Given this list of marker genes UFD1, HYDIN, KMT2D, CEP41, TCF19, CSNK1G3, LIN7C, KIAA1217, KPNA6, EIF3J, GRM7, NEGR1, CACNA2D1, SUSD6, TRIM4, PRKAG2, KHNYN, SEZ6L, CDH2, CLU (clusterin), FBXO11, KANSL1L, HLA-G, GATAD2A, SEL1L, KCNQ3, PPIP5K2, TEX35, ZNF124, ANK2, LIMD2, ANKRD13A, MAPK10, ELAVL4, OPHN1, MVB12B, PYURF, PSMC6, NGEF (NCBI Gene Id 25791), LRRC73, MAGI3, HOOK3 (hook microtubule tethering protein 3), ENKD1, GBP4, KLRD1, POLR2J2, KIF5B, HPSE, PARP15, OSBPL6, VDAC1, RAB11FIP4, RIMS2, BTRC, SMG5, EPPIN, ELP1 (elongator acetyltransferase complex subunit 1), KLF17, CENPS, NXPH1, ZNF131, ABCF2, GLIPR1L2, NOTCH2, SPC25, IDH3A (NCBI Gene Id 3419), PIP5K1C, XKR9, RNF38, FNDC5, CD3E, UBE2G1, CPEB3, CSMD3 (NCBI Gene Id 317683), TRIM71, PAIP1 (poly(A) binding protein interacting protein 1), HOXD13, CCDC140, HIF1AN, SAMD9 (NCBI Gene Id 54809), SLAIN2, MAP4K4, TNFRSF21, USP38, CD276, FGF5, HLA-DPB1, TCAF2, ZFPM2, RGS4, SLC9A4, ZFAND5 (zinc finger AN1-type containing 5), MBNL1, POLR2J3, NFIB, here is a description of the gene set: species: Homo sapiens from publication Chen Y, Wang X (PMID 31504780) Genes predicted to be targets of miRBase v22 microRNA hsa-miR-7156-3p in miRDB v6.0 with MirTarget v4 prediction scores > 80 (high confidence targets). Human Gene Set: MIR7156_3P